The following is a description of a gene set: part of: Signaling by Activin studied in species Homo sapiens Both Follistatin (FST) and Follistatin-like-3 (FSTL3) irreversibly bind Activin dimers and prevent Activin from interacting with its receptor. Though functionally similar in vitro, FST and FSTL3 do not function identically in vivo. Mice lacking FST die shortly after birth due to defects in muscle and bone; mice lacking FSTL3 are viable but have altered glucose metabolism. Reactome Pathway: Antagonism of Activin by Follistatin, and this is the list of marker genes: FSTL3 (follistatin like 3), INHBA, INHBB, FST